Given this list of marker genes MAPK11, MAPK14, MAPK12, PPARGC1A, PRKAB2 (protein kinase AMP-activated non-catalytic subunit beta 2), PRKAG2, PRKAG3, PRKAG1, PRKAB1, PRKAA2, here is a description of the gene set: species: Homo sapiens Human Gene Set: REACTOME_ACTIVATION_OF_PPARGC1A_PGC_1ALPHA_BY_PHOSPHORYLATION Activation of PPARGC1A (PGC-1alpha) by phosphorylation